Given this list of marker genes HIP1, CENPM, MTFP1, E2F8, SPRY4, BIRC5, CENPQ, ADCY3, FDXR, TCF19, NUP205, RAD54L, AURKB, DEPDC1, PLK3, PTTG1, EIF5A, GTSE1, SKA1, PIP4K2A, HELLS, GPI, HS3ST1 (heparan sulfate-glucosamine 3-sulfotransferase 1), CCDC138, TFDP1, ZMYND19, DNMT1, PSMC3IP, PSIP1, HS6ST2 (heparan sulfate 6-O-sulfotransferase 2), SNRPA1, GMPS, SIGMAR1, F12, NUP107, POLE2, HMGB3, MYO19, XDH, HMMR, RAD51, SLC43A3 (solute carrier family 43 member 3), UTP18, TTK, HOOK1, MALL, CHAF1B, RPL39L, CCNE1, SNRPB, GMDS, TYMS, UCK2, ESCO2, NCAPG2, RRM2, DSCC1, SASS6, CDC42EP4, HJURP, RFC5, CKS2, CENPL, TTF2, GINS2, RRM1, PNP, CDC6, CCNA2, HNRNPA2B1, RAPGEF5, FANCA, ERCC6L, LMNB2, TUBA1B, POLA1 (DNA polymerase alpha 1, catalytic subunit), CTNNAL1, DNAAF5, POLD3, CCDC88C, DHRS13, ERO1A, WDR76, NUDT1, MCM6, EXO1, NT5E, IER5, MDFI, FBP1, NUSAP1, KIF11, KHK, FAM72D, HPRT1, CKAP2, RFC3, NUP37 (nucleoporin 37), TMEM97, TTLL12 (tubulin tyrosine ligase like 12), MDC1, BCL2L12, SAP30, EBP, DEK, ORC1, WDR4, PRC1, MCM10, S100A14, TK1 (NCBI Gene Id 7083), POC1A, RBM14, VDR, RIN1 (Ras and Rab interactor 1), EPB41L4B, ADORA1, KIF18B, CEP85, TOMM5, HNRNPA3, DUSP6, DUSP5, ACSL5, CENPH, PLK1, SNRNP40, BRCA2, NUP62CL, GRAMD4, CDCA4, CDC7, TRIP13, BARD1, G0S2, KIF22, RAB38, MSH6, UBE2C, RAP1GAP, CDK2, SLBP, DHRS11, FUS, POC1B, CENPA, CDT1, DCK, SMC4, RFFL, RACGAP1, ACYP1, TOR3A, PGAM1, POLR3K, CKS1B, GAPDH, CCND1, NUP62, RBL1, MST1R, FOSL1, MET, MASTL, POLQ, RGS17, CDC25C, BRI3BP, ETV5, ACACA, DCTPP1, HMGA2, FASN, STIL, MND1, SDC1, SPATA13, MCM2, POLD2, KIF15, NDE1, SMC6, CIT, THOP1, CDK1, TOPBP1, CRABP2, CDCA5, DHTKD1, NEIL3 (NCBI Gene Id 55247), INSIG1, KPNA2, ACOX2, RAD51AP1, CPSF4, HMGCS1, LRRC45, STAMBPL1, KNTC1, DONSON, CDC25B, ASPM, MELK, BRCA1, LDLR, LMNB1, HNRNPD, SLC25A10, HSPA14, SMS, CHEK2 (NCBI Gene Id 11200), DTL, CEACAM1, ARHGAP19, ENO1, CENPW, BLM, LAT2, PA2G4, PADI3, BORA, MFSD2A, FOXM1, RPH3AL, KIF2C, SIVA1, TMT1B (thiol methyltransferase 1B), RFWD3, DHCR24, SMC2, NEK2, TUBG1, DDIAS, TONSL, AURKA, E2F2, RPA3, TBC1D8 (TBC1 domain family member 8), MYEOV, ZNF695, CDC25A, FANCG, SLC25A19, BUB1, GSTO2, COQ3, FANCE, LIPG, ILF3, STMN3, CS, TRIB2, CENPF, HAUS7, FEN1, ZWINT, CEP128, POLE, CLSPN, CAPN8, DHRS9, CEP55, ALDOA, UBE2T, BSPRY, SSRP1, SMC3 (structural maintenance of chromosomes 3), ARHGEF39, MYB, CHAF1A, KIF20B, PADI1, PDSS1, ACOT7 (acyl-CoA thioesterase 7), ANKRD22, ASF1B, HAUS8, TAF5, SOX2, SPRED2, GALE, VRK1, MPHOSPH9, PPARG, GTF3C6, CHEK1, KIFC1, CENPK, INTS8, MCM7, NCAPG, HMCES, RNASEH2A, HMGA1, TBC1D30 (NCBI Gene Id 23329), PAQR4, RALB, CDCA3 (NCBI Gene Id 83461), STK39, GINS3, DEPDC1B, CENPO, NUDT8, GLE1, RMI1, ELOVL6, SNRPA, HNRNPL, ACAT2 (NCBI Gene Id 39), INCENP (inner centromere protein), TIMELESS, MMS22L, THOC3, SNRPF, CCNB2, ANP32B, WRAP53 (WD repeat containing antisense to TP53), NEMP2, UBASH3B, CBX5, ADORA2B, ARHGAP11A, DAZAP1, MCM3 (minichromosome maintenance complex component 3), FBXO5, MAPK13, RAD51C, MTFR2, PHLDA2, NCAPD2, TICRR, MNS1, CENPP, FDFT1, CDCA7, HAS3, NRP1, PSRC1, KIF4A, NASP, ZNF367, FAM83D, UHRF1, FADS1, MLKL, SHCBP1, RMI2, PAX9, TPI1, NME1, NUDT15, NCAPH, PLEK2, WDR62, ANLN, LRR1, CENPN, FANCI, TRAIP, RANBP1, CEP78, DNAJC9, FOXA1, UNG, RFC2, IGFBP2, CDC20 (cell division cycle 20), FOXD1, HMGB2, PUS1, PLK4, PARP1, FGFBP1, SHMT1, MSH2, CLN6, CCNF, MTHFD1, PKMYT1, PHF19, TRA2B, E2F1, YEATS4, NTHL1, KNSTRN, CDCA8 (cell division cycle associated 8), IMPA2, DLEU1, SUV39H1, MCM5, DUT, HNRNPAB, SAPCD2, SAC3D1, MIS18A, DLGAP5, AUNIP, UBE2S, RNF157, BUB1B, CENPE, LYAR, OIP5, ETV4 (ETS variant transcription factor 4), NUP50, PBK, DCLRE1B, PHLDA1, PASK, ATAD5, NUP85, PARP2, SLC45A3, NCAPD3, TUBB4B, EME1, KIF20A, HNRNPM, ATAD2, ZNF551, EFHD2, SMC1A, TACC3, GGCT, HNRNPF (NCBI Gene Id 3185), TOP2A (NCBI Gene Id 7153), SKA3, SLF1, LAMP3, XRCC2, MAD2L1, POLA2, LMNA, SCD, MKI67, FIRRM (NCBI Gene Id 55732), TIPIN (NCBI Gene Id 54962), CDC45, CENPU, KIF23, KIF14, EPN3, DHFR (NCBI Gene Id 203373), GPSM2, ECT2, USP1, CSTF2, ESPL1, LBR, HAT1, PLP2, MCM4, BRIP1, XRCC3, PRR11, CDCA2, CCNB1, NDC1, DHX9, LRRC20, TROAP, TPX2 (NCBI Gene Id 23477), SPAG5, NDC80, LRP8, PHC2, FIGNL1, RAPGEF3, EML4, LIG1, TMPO, SPC24, ZWILCH, LIN9, CKAP2L, SHPK, BOLA3, SPC25, SH3BP1, MYBL2, EXOSC9, RPP25, ALYREF, NUF2, PCNA, WDHD1, MROH6, CDKN3, FAM81A, GINS4, STEAP1, HK2 (NCBI Gene Id 3099), PRIM1, FANCD2, RFC4, here is a description of the gene set: Drug-tolerance has emerged as one of the major non-genetic adaptive processes driving resistance to targeted therapies such as tyrosine kinase inhibitors (TKI) in non-small cell lung cancer (NSCLC). To identify potential hallmarks of drug-tolerant cells (DTC), we performed RNAseq and scRNAseq experiments using different models of EGFR-mutant DTC that emerged in response to EGFR-TKI (erlotinib or osimertinib) after 7-to-21 days of treatment. We combined our transcriptomic data with publicly available resources to generate a signature of drug-tolerance consisting in the most commonly overexpressed (p<0.01, Log2FC>0.5) or downregulated (p<0.01, Log2FC<0.5) genes in at least 6 out of 7 models. Genes commonly down-regulated (p<0.01, log2FC<0.5) in drug-tolerant cells that emerged in response to EGFR-TKI treatment (osimertinib or erlotinib) in at least 6 out 7 models of EGFR-mutant non-small cell lung cancer Human Gene Set: FIGAROL_EGFR_TKI_DRUG_TOLERANT_CELL_DN from publication Figarol S, Delahaye C, Gence R, Doussine A, Cerapio JP, Brachais M, Tardy C, Béry N, Asslan R, Colinge J, Villemin JP, Maraver A, Ferrer I, Paz-Ares L, Kessler L, Burrows F, Lajoie-Mazenc I, Dongay V, Morin C, Florent A, Pagano S, Taranchon-Clermont E, Casanova A, Pradines A, Mazieres J, Favre G, Calvayrac O (PMID 38937474) studied in species Homo sapiens